The following is a description of a gene set: studied in species Homo sapiens In this study, we examined differential gene expression in naïve human CD4+ T cells, as well as in effector Th1, Th17-negative and Th17-enriched CD4- T cell subsets. We observed a marked enrichment for increased gene expression in effector CD4+ T cells compared to naive CD4+ among immune-mediated disease oci genes. Within effector T cells, expression of disease-associated genes was increased in Th17-enriched compared to Th17-negative cells. We used microarray to examine the gene expresssion profile and level of human naïve, Th1 and effector T cell subsets. Genes down-regulated in CD4 T cells: naïve versus Th17 negative. from publication Zhang W, Ferguson J, Ng SM, Hui K, Goh G, Lin A, Esplugues E, Flavell RA, Abraham C, Zhao H, Cho JH (PMID 22715389) Human Gene Set: GSE32901_NAIVE_VS_TH17_NEG_CD4_TCELL_DN, and this is the list of marker genes: SCGN, CPD, CPNE5, ADAMTS8, MAST1, CCL4, LRRC3, CNTN4, CD79B, TULP3, SRM, SLC26A8, TSC22D3, LRCH2, SHC4, LAT2, RXFP3, ADAM2, NFE2, CSK, MIR125A, COL5A2, CPZ, ASIC1, TWNK, KCNMA1, E2F7, GUCA2B, CLEC12A, UBE2M, PTN, CETN1, DLGAP5, IFI30, PROM1, BCAS1, WDFY4, NPFFR1, INHBA, BEND4, LRRIQ1, SLC38A4, CCDC112, HEPACAM2, POLQ, KRT78, PLG, TNFRSF13B, FCMR, HOXC5, MIR129-1, ATP6V1G3, DNASE1L2, CDC20, PEBP1, MYL1, LACTB, EXO1 (NCBI Gene Id 9156), DTL, GRIA2, TUBD1, IFRD2, KCNQ4, MKI67, FJX1, CD83, UNC93B1, PLD4, BLNK, CD68, CD74, BFSP1, TCF19, ABAT, TPX2, CCBE1, MYO1B, SLC6A4, ANKS1B, NCF1, IFNA4, TNFRSF9, UPK3B, SLC8A3, NANOG, KYAT3, ANLN, MMRN2, TNFRSF13C, GFRA1, PLP2, SYT10, MIR384, TRIP13, COL22A1, CLEC4F, CFAP184 (cilia and flagella associated protein 184), MYBL2 (NCBI Gene Id 4605), PAFAH1B3, CCNE1, IGF1, INA, ZC3H10, SEMA7A, ARHGAP8, RPS4Y2, H3C4, RGS16, HOXB13, CXXC5, CCDC146, SRSF2, MSX2, TNFAIP6, AOC3, CKAP2L, ODC1, XIRP2, PTPRK, MYOM2, TNC, SERPINA9, KRT36, JPH3, GALR1